Given this list of marker genes TCOF1, SF1-DT, TOR3A, ISL2, CBX2, RAB4B-EGLN2, LIVAR, CA11, C5orf34, DDIT4, RHCE (Rh blood group CcEe antigens), KLHDC9, TXNRD2, ZNF555, MXI1, SCAPER, FARP2, MALT1, PLEKHM3, TRIM26, RASIP1, ZBTB32, EPC1-AS2, LINC01547, RERE, WDR81, RAB39A, WNK4, BHLHE40, TDRKH, DAPK1, ICE1, FBXO21, CCDC88C, TBC1D4, FAHD1, PREPL, LRP12, OSER1, BCL9L, HNRNPD, DNAJB5-DT, QTRT2, RPA1, ERCC1, FGFR4, JMJD1C, SF1, SLC35F2, RNFT2, RNF187, ZNF596, ITSN1, WDR73, SLC35E2A, KDM3A, ENSG00000274248, RN7SKP249, MOAP1, NUDT15, HDAC7, CCDC88A, SLX9, LINC00963, PYCR1, CDCA7 (NCBI Gene Id 83879), FBXO25, TNRC18, PAFAH1B3, AFMID, PDCD6IPP2, FBXO33, FAM83A-AS2, CDC40, POLDIP3, SYNCRIP, ZEB2, SHOX2, UPP2, CCN1, KBTBD7 (kelch repeat and BTB domain containing 7), SMIM15, RASSF4, MNX1, CYP2R1, AZGP1P2, ACVR1, LMNB1-DT, TK1, NKAPP1, CSNK1D (NCBI Gene Id 1453), EIF2S3, MID1IP1-AS1, TUBBP5, IRGQ, ST7-OT4, SNAP47, REX1BD, TDRKH-AS1, GAL3ST4, PWWP2A, S1PR1, CNBP, PIGQ, ZNF576, RNVU1-30, LNCTSI, RNPEP, VIM, CHEK2, OR1AB1P, HERPUD1, PTGDS, CAMSAP2, GAPVD1, HLA-DMA, LINC01126, PALS1 (NCBI Gene Id 64398), PIK3C2B, MID1IP1, ATP5F1E, CAPN10, ACVR2A, LRRC7, EMC9, ACO2, LINC02366, ST7, FZD1, NDUFS7, ELAC1, JMJD4, ATG3, RABGAP1, GPR107, LRRC27, MME, MYADM (myeloid associated differentiation marker), WWP1 (NCBI Gene Id 81891), VEGFA (NCBI Gene Id 7422), KMT2A, SPRING1 (NCBI Gene Id 79794), FRG1HP, MSANTD2-AS1, ETS2, CLOCK, OSER1-DT, PCOLCE-AS1, AGTPBP1, MPV17L2, EPB41, RBPJ, NAA16, RNASE4, HIC1, UHRF1, MYADM-AS1, CRYZL1, THEM6, FAM135A, C16orf89, TMEM41A, RIOK2, DNAJB5, TMEM181, ENSG00000236543, HEY1, SAPCD2, NR2C1, RAB4B, MEIS1, MSANTD2, GFER, KEAP1, IMPA2, SRRM5 (NCBI Gene Id 100170229), TRIM2, CAMTA2, LRRC32, WHAMM, SLC25A36, ZNRF2, UBAP1L, CARHSP1, FOSL2, NR2F2-AS1, SLC12A5-AS1, CCNG2, ESCO2, BRWD1, FADS3, POU3F2, GNAS, CRBN (NCBI Gene Id 51185), SUZ12P1, TRIOBP, ZFP36L2, PGAP6, UBE2D4 (ubiquitin conjugating enzyme E2 D4), PPP6R1, FAR1, COX16 (NCBI Gene Id 51241), PCBD1, CAMKMT, KCNH2, TMEM243, BRD2, SYT8, EBF4, KIAA0319, S1PR1-DT, STPG1, CYP1B1-AS1, MIR22HG, SLC12A5, RWDD1 (NCBI Gene Id 82733), ARID1A, RPL23AP53, PATL1, PLCXD2, CTIF, STARD3NL, HOXA-AS2, RPS6KL1, ENSG00000274253, ITGA3, BRMS1, HAGH, ROR2, NADK, CCDC191, RPL32, GBA1, LMNB1, PRKCE, B4GAT1-DT, PNRC1, SSBP2, RRM2, TTL, CTDSP2, CTNNB1 (catenin beta 1), SMYD4, MNX1-AS1, ARHGEF12, LIPT2-AS1, HSCB, KBTBD11-AS1, CAT (catalase), E2F3, MEF2A, FAT1, MOV10, URGCP, IL10RA, DBP, PCOLCE, H3P2, POLD3, CAST, FAM83A, NOTCH2NLA, PSPH, WASF1, PHF21A, PHF5A, FAR1-IT1 (NCBI Gene Id 106478978), SLC22A11, STEAP1B, VPS37D, CBLN1, HELLS, B4GAT1, CTTNBP2 (NCBI Gene Id 85447), RERE-AS1, TSPAN14, SCN9A, AKTIP, CARHSP1-DT, ACBD5, TIGAR, RPL32P3, DIP2A, SERPINH1 (serpin family H member 1), HNRNPD-DT, MEIS1-AS3, MACO1, ANG, here is a description of the gene set: studied in species Homo sapiens from publication Yevshin I, Sharipov R, Kolmykov S, Kondrakhin Y, Kolpakov F (PMID 30445619) Genes containing one or more binding sites for (PHF21A) in their promoter regions (TSS -1000,+100 bp) as identified by GTRD version 20.06 ChIP-seq harmonization. Human Gene Set: PHF21A_TARGET_GENES